The following is a description of a gene set: Human Gene Set: GOBP_GANGLIOSIDE_BIOSYNTHETIC_PROCESS_VIA_LACTOSYLCERAMIDE species: Homo sapiens The chemical reactions and pathways resulting in the formation of gangliosides that begins with the formation of lactosylceramides, Gal-beta-(1->4)-Glc-beta-(1->1') ceramides, any compound formed by the replacement of the glycosidic C1 hydroxyl group of lactose by a ceramide group., and this is the list of marker genes: ST3GAL1, B4GALT6, ST3GAL2, B4GALT5, C20orf173, ST3GAL3